Given this list of marker genes BAD, PIK3CD, PIK3CA, NRAS, AKT1, PIK3CB, KRAS, AKT3, AKT2, here is a description of the gene set: species: Homo sapiens Human Gene Set: KEGG_MEDICUS_VARIANT_MUTATION_ACTIVATED_KRAS_NRAS_TO_PI3K_SIGNALING_PATHWAY Pathway Definition from KEGG: (KRAS*,NRAS*) -> PI3K -> PIP3 -> AKT -| BAD Mutation-activated KRAS/NRAS to PI3K signaling pathway. Pathway ID: N00032. Pathway type: Variant. Pathway class: nt06260 Colorectal cancer.